The following is a description of a gene set: Mouse Gene Set: GOMF_TUBULIN_BINDING species: Mus musculus Binding to monomeric or multimeric forms of tubulin, including microtubules., and this is the list of marker genes: Spmip6, Spatc1, Bex4, Ftcd, Cript, Kif1b, Cep350 (NCBI Gene Id 74081), Cep295, Birc5, Map1lc3b, B9d2, Spag8, Eml5, Haus6, Cacybp, Ckap5, Bloc1s2, Kif23, Mapt, Kif19b, Appl1, Haus8, Kifc5b, Map6d1, Agbl5, Strbp, Cetn3, Agbl1, Reep2, Kif28, Eml1, Kif22, Nedd1, Uxt, Cfap157, Tubgcp3, Ttll9, Map2, Dnm2, Tbcb, Hdgfl3, Ccdc88a, Cimap3, Ccdc69, Stim1, Hook2, Rcc2, Arl3, Map9, Neil2, Kif24, Spaca9, Klc3, Ttll12, Spag6, Phf6, Ccsap, Htt, Nlrp5, Cep57, Trim46, Ift74, Dclk2, Kif18a, Nme8, Jmy, Ttll11, Clxn, Nuf2, Kif13a, Cetn2, Ndrg1, Mast2, Kif14, Ogg1, Knl1, Ccdc88b, Gas2, Rmdn3, Bcl2l11, Gtse1, Svbp, Apc, Mapre2, Kif5c, Kif5b (NCBI Gene Id 16573), Cep44, Kif2b, Kif4 (NCBI Gene Id 194650), Tbcel, Kif15, Akap1, Nav3, Setd2, Ino80, Tppp3, Ska3, Dync1i1, Dst, Terf1, Lrpprc, Numa1, Cav3 (NCBI Gene Id 12391), Jakmip3, Stmn2, Fam110c, Map7d3, Nde1, Rad51d, Dnm1l, Stmn3, Sbds, Adnp, Stard9, Kif2a, Tubgcp5, Gnas, Kif1a, Kifc1, Fmn1, Tubgcp2, Ttll1, Gas8, Cep290, Katnbl1 (katanin p80 subunit B like 1), Maco1, Pde4b, Brca2, Fgf13, Tbca, Tpr, Stmn1, Arl8b, Cgn, Ccdc170, Cep57l1, Mtus1, Gas2l1, Rmdn2, Slc6a2, Plk1, Spire1, Spire2, Cenpe, Ccdc181, Tbcc, Gli1, Togaram2, Rgs14, Kif11, Ift81, Ssna1, Dysf, Krit1, Nusap1, Gas2l2, Mapre1, Chp1, Hdgf, Katna1, Unc5c, Fes, Dnm1 (NCBI Gene Id 99078), Ndc80, Gapdhrt, Spast, Bccip, Psrc1, Togaram1, Clip3, Wipf3, Zfp207, Fez1, Spata4 (spermatogenesis associated 4), Ezr, Nme1, Polb, Sgip1, Ccdc61, Lrrc61 (leucine rich repeat containing 61), Ppargc1a, Bcas3, Fmn2, Washc1, Gapdhrt2, Dyrk1a, Dnal1, Vapb, Sybu, Hsph1, Pex14, Hdac6, Prnp, Rab11a, Syt11, Kif12, Map4 (NCBI Gene Id 235620), Lrrk2, Tbcd, Reep1, Saxo2, Kifc3, Map1a, Kif3c, Mtus2, Sncb, Gja6, Pak1, Vbp1, Mtcl1, Kif5a, Appbp2, Eml3, Fbxw11, Capn6, Irag2, Fyn, Kif13b, Smc3, Clip1, Kif2c, Cenpj, Haus7, Apc2, Ccser2, Tmod3, Cetn1, Efhc1, Clasp1, Ttll13, Fhdc1, Mast1, Gapdh, Sncg, Agbl3, D1Pas1, Cryab, Pafah1b1, Trim36, Dixdc1, Kif17, Taok1, Fnta (NCBI Gene Id 14272), Nf1, Ttll6, Golga2, B4galt1, Ndn, Trim54, Ofd1, Abraxas1, Kif1c, Stmn4, Map10, Gjb6, Map4k4, Mdm1, Ttll5, Spag5, Gabarap, Map6, Kif7, Cep135, Pdcd5-ps, Arl4c, Ccdc66, Lyn, Kif16b, Vps41, Nin, Camsap2, Kif26a, Mid2, Jakmip1, Clasp2, Trappc14, Ppp5c, Reep4, Ttll4, Kif26b, Vash2, Ddx3x, Kif21b, Dag1, Fsd1, Ska1, Tubgcp4, Kif19a, Kif9, Ranbp10, Kif21a, Agbl4, Katnal1, Gas2l3, Kif3a, Ppp1r42, Eml4, Haus4, Arhgef2, Ccdc88c, Vapa, Dctn1, Bbs4, Abraxas2, Kif18b, Katnb1, Dip2b, Spag6l, Klc1, Opa1, Whamm, Pdcd5, Hook3, Kifc2, Ccdc187, Cnn3, Wdr90, Arhgef7, Macf1, Cdk5rap2, Fmr1, Tpgs1, Dnai7, Map1lc3a, Ndel1, Kif6, Dnm3, Kif20b, Katnal2, Ska2, Trpv4, Camsap1, Rps3, Gja1, Rmdn1, Prkn, Ncald, Kif3b, Rab11fip5, Camsap3, Mlph, Tiam1, Atf5 (activating transcription factor 5), Knstrn, Eml6, Snca, Tubgcp6, Agtpbp1, Cep70, Racgap1, Dlgap5 (NCBI Gene Id 97934), Brsk1, Clip4, Luzp1, Mark4, Dlec1, Mid1, Map7d2, Ttll2, Mapre3, Cct5, Spef1l, Eml2, Kif27, Enkd1, Reep3, Tbce, Rita1, Saxo1, Cfap144, Bex6, Traf3ip1 (NCBI Gene Id 98598), Mx2, Agbl2, Spef1, Rp1, Tppp2, Git1, Rgs2, Diaph3, Pacrg, Fam161a, Emd, Hook1, Kif20a, Clip2, Map1s, Spc24, Dcx, Prc1, Ttll7, Fam83d, Drg1, Tppp, Prune1, Map1b